The following is a description of a gene set: Mouse Gene Set: chr3D species: Mus musculus, and this is the list of marker genes: Tm4sf1, Aadac, Serp1, Gm16016, 1700007F19Rik, Tgif1-ps, Aadacl2fm1, Gm40055, Gm2622 (NCBI Gene Id 100040139), Eif2a, Siah2, Mindy4b-ps, Gm26671, AU022133, Gpr171, Gm8177, Gm8325, Gm33707, Med12l, Mir6377 (NCBI Gene Id 102465197), P2ry14, Gpr87, Tm4sf4, Gm4856, Rnf13, Ankub1, Rpl13-ps6, Gm18427, Gm5276, 4921539H07Rik, 4930593A02Rik, Aadacl2fm2, Aadacl2fm3 (AADACL2 family member 3), Gm2756, Gm5709 (predicted gene 5709), Gm18660, Tsc22d2, Igsf10, A930028O11Rik, BB187690, Selenot, Aadacl2, Gm6394, Gm25572, Pfn2, Clrn1 (NCBI Gene Id 229320), Wwtr1, Gm5537, Gm38326, Gm9696, Commd2, Gm8234, Sucnr1, Gm22491, Gm16527, Gm24382, Erich6, 6720482G16Rik, Gm17951, Gm18867, Gm20128 (predicted gene, 20128), Gm9645, Gm8276, P2ry13, Mbnl1, Gm26166, P2ry12, Gm5539